The following is a description of a gene set: The chemical reactions and pathways involving glyceraldehyde-3-phosphate, an important intermediate in glycolysis. Mouse Gene Set: GOBP_GLYCERALDEHYDE_3_PHOSPHATE_METABOLIC_PROCESS species: Mus musculus, and this is the list of marker genes: Pcx, Gpd1, Tpi1, Tkt, Shpk, Rpia, Eno1, Mdh1, Pgk1, Taldo1, Gapdh, Aldob, Pck1, Mdh2, Pgam1, Slc25a10, Khk, Tkfc, Rpe